The following is a description of a gene set: studied in species Homo sapiens Catalysis of the incorporation of one atom from molecular oxygen into a compound and the reduction of the other atom of oxygen to water. Human Gene Set: GOMF_MONOOXYGENASE_ACTIVITY, and this is the list of marker genes: HMOX2, AKR1C1, CALM3, FMO1, ACTB, COQ7, CYP4F2 (NCBI Gene Id 8529), CYP2C8, COQ6, CYP2C9 (NCBI Gene Id 1560), PAH, KMO, CYP2E1, CYP4V2, CYP1A1, CYP27A1, TH, CYP2A13 (cytochrome P450 family 2 subfamily A member 13), CAV1, AKR1D1 (aldo-keto reductase family 1 member D1), PCBD1, CYP2D6, NLRP11, CYP2U1, CYP2W1, CYP4Z2P, CYP26C1, AGMO, CYP2F1, CYP46A1, HMOX1, CYP2G1P, MIOX, FMO2, ESR1, SQLE, MOXD1 (monooxygenase DBH like 1), CYP39A1, FMO5, CYP2A6, CYP24A1, HSP90AA1, CYP19A1, NDUFAF5, FAXDC2, TPH2, CYP11B1, MICAL2, JMJD7, DBH, CYP1B1, AKR1C2, TYR, CYP2R1, DOHH (NCBI Gene Id 83475), FMO3, CYP3A4, NOS1AP (NCBI Gene Id 9722), NOS1, NOS3, CYP2B6, CYP27B1, TYRP1, TBXAS1, CYP11A1 (NCBI Gene Id 1583), PARK7, CYP8B1, CYP11B2, CYP4Z1, CYP4F12, TPH1, ATP2B4, CYP2S1, CYP4F22, AKR1C4, CYP4B1, NDUFS7, CYP4A22, CYP17A1, MSMO1, DEGS2, CYP4F11, FMO4, CYP7B1, CYP7A1, CYP1A2, AKT1, FA2H, MICAL1, NOS2 (nitric oxide synthase 2), DYNLL1, CYP2C19, MOXD2P, CYP4A11, CYP26A1, CYP4X1, CYP26B1, CH25H, CYP21A2, FOXRED2, CMAHP, CYP3A5, CYP4F3, AKR1C3, PAM, CYP20A1, CYP27C1, HSP90AB1, MICAL3, PTGIS (NCBI Gene Id 5740), CYP2J2, CYP4F8, CYP3A43, CYP51A1, CYP2C18, CYP2A7, CYP3A7